Given this list of marker genes GCSAM, MYL4, LLGL1, SHROOM4, TRIOBP, LIMCH1, MYL3, SHROOM1, GSN, STXBP5L, STXBP5 (NCBI Gene Id 134957), LLGL2, here is a description of the gene set: Human Gene Set: GOMF_MYOSIN_II_BINDING Binding to a class II myosin, any member of the class of 'conventional' double-headed myosins that includes muscle myosin. species: Homo sapiens